Given this list of marker genes TALDO1, CA1, ANXA2, BOLA2, SERPINB2, LMNB1 (lamin B1), TCP1, IL12RB2, PDCD4, HNRNPDL, IL27RA, IL23R, IL12B, JAK2, RALA, IL6ST, PAK2 (NCBI Gene Id 9106), PPIA, HSPA9, CAPZA1, SOD1, HNRNPF, EBI3, LCP1 (NCBI Gene Id 3936), MTAP, GSTO1, PITPNA, CRLF1 (NCBI Gene Id 9244), IL27, P4HB (NCBI Gene Id 94756), CDC42, STAT4, GSTA2, SOD2, MIF, STAT3, RAP1B, HNRNPA2B1, TYK2, IFNG, MSN, STAT1, ARF1, JAK1, RPLP0, CANX (NCBI Gene Id 821), SNRPA1, IL23A, CNN2, AIP, IL12A, PSME2, VAMP7, IL12RB1, CFL1, IL10, here is a description of the gene set: species: Homo sapiens part of: Signaling by Interleukins Interleukin-12 (IL-12) is a heterodimer of interleukin-12 subunit alpha (IL12A, IL-12p35) and interleukin-12 subunit beta (IL12B, IL-12p40). It is a potent immunoregulatory cytokine involved in the generation of cell mediated immunity to intracellular pathogens. It is produced by antigen presenting cells, including dendritic cells, macrophages/monocytes, neutrophils and some B cells. It enhances the cytotoxic activity of natural killer (NK) cells and cytotoxic T cells, stimulating proliferation of activated NK and T cells and induces production of interferon gamma (IFN gamma) by these cells. IL-12 also plays an important role in immunomodulation by promoting cell mediated immunity through induction of a class 1 T helper cell (Th1) immune response. IL-12 may contribute to immunopathological conditions such as rheumatoid arthritis. The receptor for IL-12 is a heterodimer of IL-12Rbeta1 (IL12RB1) and IL-12Rbeta2 (IL12RB2), both highly homologous to Interleukin-6 receptor subunit beta (IL6ST,gp130). Each has an extracellular ligand binding domain, a transmembrane domain and a cytosolic domain containing box 1 and box 2 sequences that mediate binding of Janus family tyrosine kinases (JAKs). IL-12 binding is believed to bring about the heterodimerization and generation of a high affinity receptor complex capable of signal transduction. In this model, receptor dimerization leads to juxtaposition of the cytosolic domains and subsequent tyrosine phosphorylation and activation of JAK2 and TYK2. These activated kinases, in turn, tyrosine phosphorylate and activate several members of the signal transducer and activator of transcription (STAT) family, mainly STAT4, while also STAT1, STAT3 and STAT5 have been reported to be activated. The STATs translocate to the nucleus to activate transcription of several genes, including IFN gamma. The production of IFN gamma has a pleiotropic effect in the cell, stimulating production of molecules important to cell mediated immunity. In particular, IFN gamma stimulates production of more IL-12 and sets up a positive regulation loop between IL-12 signaling and IFN gamma. The importance of IL-12 for this loop is demonstrated by IL-12 and STAT4 knockout mice that are severely compromised in IFN-gamma production, as well as by patients with IL12B mutations that are severely compromised in IFN-gamma production (Altare et al.1998). Reactome Pathway: Interleukin-12 family signaling